Given this list of marker genes ENPP1, HLA-B, PTPN22, DMP1, IL2RA, ANKRD55, PTPN2, STAT4, CD247, IL2RB (NCBI Gene Id 3602), PHEX, here is a description of the gene set: Human Gene Set: HP_ENTHESITIS species: Homo sapiens Enthesitis